The following is a description of a gene set: species: Homo sapiens Binds to and decreases the activity of the ligand of a signaling receptor. Human Gene Set: GOMF_RECEPTOR_LIGAND_INHIBITOR_ACTIVITY, and this is the list of marker genes: NRROS, LTBP1, IGFBP2, LRRC32, NOG, LGALS3, HSP90AB1, TMEFF1